The following is a description of a gene set: Mouse Gene Set: GOBP_REGULATION_OF_RIBOSOME_BIOGENESIS Any process that modulates the rate, frequency or extent of ribosome biogenesis. Ribosome biogenesis is the cellular process that results in the biosynthesis of constituent macromolecules, assembly, and arrangement of constituent parts of ribosome subunits. studied in species Mus musculus, and this is the list of marker genes: Cdkn2a, Rbm10, Mettl18 (methyltransferase like 18), Nudt16, Usp16, Kat2b, Pten, Malsu1